The following is a description of a gene set: species: Mus musculus Mouse Gene Set: GOMF_GUANYLATE_CYCLASE_REGULATOR_ACTIVITY Modulates the activity of guanylate cyclase., and this is the list of marker genes: Guca1b, Guca1a, Nherf4, Guca2b, Ncs1, Guca2a